Given this list of marker genes Fadd, Casp8, Tnfrsf10b, Tnfsf10, Cflar, here is a description of the gene set: Mouse Gene Set: REACTOME_TRAIL_SIGNALING species: Mus musculus TRAIL signaling